The following is a description of a gene set: species: Homo sapiens Human Gene Set: GOBP_THYROID_HORMONE_RECEPTOR_SIGNALING_PATHWAY A nuclear receptor-mediated signaling pathway initiated by a thyroid hormone binding to an intracellular receptor of the nuclear receptor protein family, and ending with regulation of a downstream cellular process, e.g. transcription., and this is the list of marker genes: THRA, MED1, PRCP, RXRA, THRB, NCOA1, MIR208A, GPHB5